The following is a description of a gene set: part of: Branched-chain amino acid catabolism electronically inferred by orthology from the curated human pathway species: Mus musculus Reactome Pathway: BCKDH synthesizes BCAA-CoA from KIC, KMVA, KIV This event has been computationally inferred from an event that has been demonstrated in another species.<p>The inference is based on the homology mapping from PANTHER. Briefly, reactions for which all involved PhysicalEntities (in input, output and catalyst) have a mapped orthologue/paralogue (for complexes at least 75% of components must have a mapping) are inferred to the other species., and this is the list of marker genes: Dld, Bckdhb